Given this list of marker genes Inhba, Acvr2a (activin receptor IIA), Chrdl1, Grem2, Bmp10, Smurf1, Zfyve16, Amh (NCBI Gene Id 11705), Smad6, Smad9, Fstl1, Nog, Smurf2, Smad1, Ube2d1 (ubiquitin-conjugating enzyme E2D 1), Acvrl1, Smad7, Gdf2, here is a description of the gene set: part of: Signaling by TGFB family members This event has been computationally inferred from an event that has been demonstrated in another species.<p>The inference is based on the homology mapping from PANTHER. Briefly, reactions for which all involved PhysicalEntities (in input, output and catalyst) have a mapped orthologue/paralogue (for complexes at least 75% of components must have a mapping) are inferred to the other species. studied in species Mus musculus Reactome Pathway: Signaling by BMP electronically inferred by orthology from the curated human pathway